The following is a description of a gene set: Human Gene Set: MIR12121 studied in species Homo sapiens from publication Chen Y, Wang X (PMID 31504780) Genes predicted to be targets of miRBase v22 microRNA hsa-miR-12121 in miRDB v6.0 with MirTarget v4 prediction scores > 80 (high confidence targets)., and this is the list of marker genes: BRINP3, ZNF730, ZNF28, ZNF732, ZNF728, ZNF117, ARHGEF15, GPR158, ZNF99 (NCBI Gene Id 7652), GRIP1, MRAS, MSRA, LNPEP (leucyl and cystinyl aminopeptidase), ZNF737 (NCBI Gene Id 7655), GPR107, ZNF107, ZNF600 (NCBI Gene Id 162966), ZNF493, ZNF138, ZNF208, ZNRF3, ZNF676, BPTF, OXR1, PDCD10, ZNF468, ZNF708